The following is a description of a gene set: Mouse Gene Set: GOMF_CHLORIDE_ION_BINDING studied in species Mus musculus Binding to a chloride ion (Cl-)., and this is the list of marker genes: Wnk4, Amy2a2 (NCBI Gene Id 100043688), Amy2a3, Nlgn4l, Tdg-ps, Tdg, Nudt16, Amy2a4, Ctsc, Ace, Amy2a5, Nqo2, Npr3, Slc22a6, Amy1, Amy2a1